The following is a description of a gene set: Any process in which a lipoprotein is transported to, or maintained in, a specific location. species: Homo sapiens Human Gene Set: GOBP_LIPOPROTEIN_LOCALIZATION, and this is the list of marker genes: MIA3, MIA2, MIR301B, PREB, CUBN, MIR148A, UNC119, SURF4, MSR1, SAR1B, ZDHHC3, PPARG, APOB, ZDHHC17, PRKCB, LRP1, APOE, MTTP, CD36, SAR1A, PGRMC1, TMEM97, APOBEC1, UNC119B, MIR128-1, MIR130B, VMP1